Given this list of marker genes Met, Ska3, Nusap1, Ins1, Cd28, Ereg, Anapc7, Tgfa, Igf1r, Sphk1, Pebp1, Cdc23, Phip, Cdc20, Smpd3 (sphingomyelin phosphodiesterase 3, neutral), Igf2, Pdgfrb, Igf1, Lrp5, Rgcc, Tnf (tumor necrosis factor), Rb1, Mad1l1, Hoxa13, Btc, Pdgfb, Drd3, Fgf8, Prap1, Ube2c (NCBI Gene Id 68612), Nup62, Dmrt1, Insr (insulin receptor), Ins2, Il1a, Ska1, Cdc16, Cul3, Egf, Anapc5, Nsmce2, Mad2l1bp (MAD2L1 binding protein), Cenpe, Epgn (epithelial mitogen), Sh2b1, Il1b, Anapc11, Edn3, Edn1, here is a description of the gene set: studied in species Mus musculus Any process that activates or increases the frequency, rate or extent of mitosis. Mouse Gene Set: GOBP_POSITIVE_REGULATION_OF_MITOTIC_NUCLEAR_DIVISION